Given this list of marker genes NPIPB13, TOB2 (NCBI Gene Id 51445), SLC35F3, KLHL2, GPBP1, IGF1, MAGI1, PDE7B, PLEKHG7, RFC5, PDE3B, COMMD10, CTNND1, CBL, PTEN, TMBIM6, SDC2, ARHGAP32, HEATR1, LEKR1, PHACTR2, TRIM34, TLX3, ZBTB20, TRIM6-TRIM34, SALL1, BCL6B, THEMIS, TARDBP, JPH4, LHFPL1, FTO, BAG1, FAM91A1, DARS2, NUBP1, ACTR3, CRYBG3, KIF20B, TUBE1, PPM1A, EIF1AX, PPIP5K1, NPR3, MBNL3, RUNX1T1, MEIOC, C3orf52 (chromosome 3 open reading frame 52), ACOX1, PAK6-AS1, EIF4EBP2, ZNF518B (zinc finger protein 518B), DSEL (dermatan sulfate epimerase like), HNRNPU, CHRNA5, TRDN (NCBI Gene Id 10345), SLC4A7, SLC16A1, ALOX5AP, GTF3C3, CENPF, NAA16, M1AP, MECP2, GRIK1, EFEMP1, ZNF514, PHRF1, KLF5, STK17B, NCKAP5, APH1B, DPH6, COBLL1, RIOK2, SUCLA2, SHCBP1, IL17D, MED26, ANKS1A, SDE2, MAP3K2, ALKAL2, ENTPD5, MON2, RABEP1, GPM6B, CLEC2D, RNF17, PHC3, RFX3, SLC6A11, L3MBTL4, GNG2, TEAD1 (TEA domain transcription factor 1), TLE4, PPM1F, REPS2, PPP2R5C, SNUPN, TRPC6, HMBS, REEP1, PPM1B (protein phosphatase, Mg2+/Mn2+ dependent 1B), TRMT10A, RNF139, OXGR1, HIBADH, PRELP, GPR143, PDIA6, SLC39A1, TMEM106B, LSS, ZMAT3, CWC15, CLRN1, HEPH, CYB5B, CMPK2, KDM6A, FBN2, TAF5L, DGKH, RYBP, CDC73 (NCBI Gene Id 79577), CDK6, VCPIP1, PSIP1, ANKRD50, CPED1, PTBP2, NTRK2, PHEX, PATZ1, DHX15, RAP2A, ZIC4, CLPX, RBFOX1, INO80D, TCEAL6, COL6A6, ARL5B, HABP2, REPS1, TBL1XR1, FAM83B, RGL4, DENND1B, SLK, RALGPS1, DUSP11, PRRG1, AFG1L, RFXAP, TNRC6B, ZKSCAN8, RASAL2, ABCC5, ACSS3, SKP2, ITGB3, LYSET, CLTA, RGS5, CCN4, C17orf58, ZSCAN25, ZBTB18, KL, CAMLG, SENP6, UBE2B, ALCAM, here is a description of the gene set: Human Gene Set: MIR4744 Genes predicted to be targets of miRBase v22 microRNA hsa-miR-4744 in miRDB v6.0 with MirTarget v4 prediction scores > 80 (high confidence targets). from publication Chen Y, Wang X (PMID 31504780) species: Homo sapiens